Given this list of marker genes CCDC190, TET1, PCSK6, GFM2, QSER1, STEAP2, EXT1, ZIC3, MOB1A, C14orf39, ELAVL3, ZMIZ1, PCDHA5, ALCAM, PCDHA10, AMMECR1, UNC5A, UGT8, MAFG, CALU (calumenin), ANKRD33B, ZNF514, ZNF420, PIAS2 (NCBI Gene Id 9063), WDR41, AFTPH, PLEKHA3, PHF13, PKP4, ELOVL2, SLC35F1, DOK6, IREB2, LARP1B, GPR37, PCDHA2 (protocadherin alpha 2), SFRP5, GLYAT, CDH11, CLASP2, IL17RB, EIF2S1, ARAF, FUT9, TFEC, PCDHA3, PPP2CA (NCBI Gene Id 5515), PHETA2, PLEKHA5, PTPRG, BACH2, NHLH1 (NCBI Gene Id 93188), RASAL2, PPIL4, TRIM43B, DUSP4, HTR4, PCDHAC2, IL2RA, SIPA1L2, CALCRL, POPDC3, YWHAG, MSANTD2, TMIGD1, PCLO, RBFOX1, HS6ST3, KCNH5, TNFRSF11A, PCDHAC1, TRPS1, CMPK1, PEG10, VAPA, MED6, AGAP2, PLEKHG3, NR2F2, ABCD2 (NCBI Gene Id 225), APPBP2, DNHD1, ZNF536, PRKCD, RAB11FIP2, RNF24, ZIC4, FAM98A, TNPO1, RSPO2, VPS36, WSB1 (NCBI Gene Id 26118), TOGARAM1, TP53RK, TCEAL9, INTU, SIPA1L1, GUCY1A1, PARP8, CTNND2, E2F7, ABCD3, SNX16, LY75-CD302, UNC5C, LRP2BP, STAB1, STK26, TMEM97, DCAF5, APC, FAM135A, PCDHA11, NAA15, MARS2, CCDC80 (NCBI Gene Id 151887), OR51E2, PCDHA7, B3GALT2, CLIC4, MSR1, DUXA, PDZD8, TXN, GPATCH11, RB1, RAP1GAP2, RAP1A, ZSCAN23, KCNN2 (potassium calcium-activated channel subfamily N member 2), TRIM43, YIPF5, GALE, LRBA, GPM6B, MTMR10, CALN1, TIMM8B, PPP6R3, ABI1, DENND10, COMMD3-BMI1, PTP4A2, PTAR1, CD302, KDM6A, CLVS1, C9orf72, TOX3, FAM3C, PCDHA8, ZNF264, ERAP1, ABTB2, ANKRD44, CREG2, CDK6, MRPS30, ELAVL2, HNRNPR, PCDHA4, MAGEB18, NDNF, BNIP2, SRGAP2C, PCDHA6, MARK1, LCLAT1 (lysocardiolipin acyltransferase 1), ACTC1, B3GALNT2, SACS (NCBI Gene Id 26278), BHMT, PCDHA12, NEK1, ABCC9, ZFAND1, HS6ST2, MARCKS (NCBI Gene Id 4082), SPATA22, KMT5B, TGFB2, TAFA1, TTC5, GCG, TPM3, SLC20A1, ENTPD3, RUNX2 (NCBI Gene Id 860), NFAT5, RNF212B, ZDHHC23, CCNG1, CACNB2, ITM2A, DNAJA4, BBX (BBX high mobility group box domain containing), CAAP1, C15orf40, SLBP, TNFRSF11B (NCBI Gene Id 4982), THAP1, RIC1, VSNL1, HCN1, PCDHA1 (NCBI Gene Id 56147), FOXJ3, ZNF510, BCL11B, PCDHA13, FSTL3, CRISPLD1, YTHDC1, ULK1, SCN8A, TUT7, SRGAP2B, SPIN1, UBE2B, SLCO3A1, MAG, PCDHA9, ZPLD1, RAB11A, ASPH, PLAG1, RO60, NCOA1, ETV1, HIGD1A, COX15, SMAD1, GPR85 (NCBI Gene Id 54329), DLX1, CCNL1, TCF21, SKAP2, LCORL, MFSD8, ANXA2R, PHIP, THRB, CXCL16, HNRNPD, SMARCAD1, FSIP1, OTOGL, here is a description of the gene set: Genes predicted to be targets of miRBase v22 microRNA hsa-miR-4703-5p in miRDB v6.0 with MirTarget v4 prediction scores > 80 (high confidence targets). Human Gene Set: MIR4703_5P studied in species Homo sapiens from publication Chen Y, Wang X (PMID 31504780)